Given this list of marker genes PTDSS1, LDLRAD4, FAM43B, TAB2, AMD1, TMEM132E, CHRAC1, MECR, SLC6A3, FAM199X, ATP6V1C1, NUTF2, GPR137, CTTN, SIM1, ONECUT2, HLA-E, SETDB2, EN1, RGS6, ZFAND3, UBN2, RIMS2, ROBO2, ODAPH, CRMP1, IPO9, TTC4, STX3, SPPL3, SYT2, MYO19, JAM2 (junctional adhesion molecule 2), IGDCC3, SORBS1, ACSM2A, FZD1, ACSL5, NECTIN1 (NCBI Gene Id 84853), ZNF641, ZMIZ1, H6PD, UBE3D, ADCYAP1R1, SECTM1, EIF5B, YWHAZ, BPTF, NR6A1, SH3PXD2A, RNF170, LMX1B, MMP8, TNFAIP1, STXBP1, NDST2, PLCH2, TPCN1, GABPB1, LVRN, CARHSP1, STOX2, MMRN1, MDM1, AGPAT3, ORMDL3 (NCBI Gene Id 94103), MMS19, FLOT2, KLHL14, LRRC4B, ZNF131, ZNF660, EPHA10, SMARCD1, ACER2, DGKG, DNM3, IL21, FOXP3, SLC34A2, OSER1, ABHD11 (abhydrolase domain containing 11), PRRG1, ARRB1, SP100, PPP1R14C, here is a description of the gene set: species: Homo sapiens Genes predicted to be targets of miRBase v22 microRNA hsa-miR-134-3p in miRDB v6.0 with MirTarget v4 prediction scores > 80 (high confidence targets). Human Gene Set: MIR134_3P from publication Chen Y, Wang X (PMID 31504780)